The following is a description of a gene set: A decreased rate of urine production. Human Gene Set: HP_DECREASED_URINE_OUTPUT Decreased urine output species: Homo sapiens, and this is the list of marker genes: ACE, CAV1, RYR1, CCN2, REN, OBSCN, AGT, THBD, PKHD1, C3, CFH (NCBI Gene Id 3076), CCR6 (NCBI Gene Id 1235), MYH11, CFB, LPIN1, CFI, SLC25A20, AGTR1, CFHR1, MT-CO3 (NCBI Gene Id 4514, mitochondrially encoded cytochrome c oxidase III), CD46, SLC22A12, APRT, CFHR3, PBX1, HLA-DRB1, PAX2, IRF5, DZIP1L, MT-CO1